Given this list of marker genes Il11, Il11ra3, Il11ra1, Jak1, Stat3, Il11ra2, Il6st, here is a description of the gene set: The series of molecular signals initiated by the binding of interleukin-11 to its receptor on the surface of a target cell, and ending with the regulation of a downstream cellular process, e.g. transcription. species: Mus musculus Mouse Gene Set: GOBP_INTERLEUKIN_11_MEDIATED_SIGNALING_PATHWAY